Given this list of marker genes COL2A1, AMELX, BGN, CTHRC1, ZP1, FBLN1, PRG2, COL12A1, EMILIN1, HMCN2, COL9A1, AGRN (agrin), ASPN, COLQ, COL6A6, COL25A1, MMRN2, COL1A2, COL5A2, NID2, MUC4, COL7A1, COL5A1, VTN, COL13A1, COL6A5, EMILIN2, ACAN, MUC3A, COL23A1, COL21A1, STATH (NCBI Gene Id 6779), OGN, TNXB, LAMA4, LAMA3, LAMC1, COL1A1, COL19A1, ESM1, THBS2, LAMB3, CHI3L1, ELN, CCN1, LAMA2, COL6A2, COL4A4, PODNL1, COL4A2, CRELD1, COL22A1, DSPP, MUC17, FGL2 (NCBI Gene Id 10875), COL6A1, COL8A2, SRPX2, EFEMP2, LAMA1, COL4A6, LAMA5, VWA1, SPOCK1, COL4A1, MGP, OPTC, ZP2 (NCBI Gene Id 7783), DCN, HSPG2, HAPLN1, AMBN, TUFT1, COL28A1, COMP, MATN3 (NCBI Gene Id 4148), COL4A3, FN1, COL9A2, FBLN5, COL18A1 (collagen type XVIII alpha 1 chain), SPON1 (NCBI Gene Id 84806), MFAP2, COL6A3 (NCBI Gene Id 1293), THBS3, LTBP2, ABI3BP, COL15A1, FBN1, FGB, SPARC, FGA, LAMB1, CHADL, POSTN, PRG4, COL5A3, COL9A3, THBS1, PODN, AEBP1, PRG3, COL4A5, ADIPOQ, MFAP5, HMCN1, TFPI2 (tissue factor pathway inhibitor 2), AMELY, FMOD, TNC (tenascin C), SBSPON, MMRN1, TINAGL1 (tubulointerstitial nephritis antigen like 1), CD4, EFEMP1, LAMC2, CILP, COL11A2, NID1, EMILIN3 (NCBI Gene Id 90187), OTOL1, EDIL3, LTBP4, COL17A1, PXDN, ENAM, IMPG2, ZP4, COL8A1, PRELP, VCAN (NCBI Gene Id 7902), MFGE8 (NCBI Gene Id 54740), NPNT, TECTA, IGFBP7, LAMB2, VWF, THSD4, HAPLN4 (NCBI Gene Id 404037), MEPE, COL14A1, COL16A1, FGG (NCBI Gene Id 2266), TGFBI, LUM, ECM1, FBLN2, MXRA5, LTBP1 (latent transforming growth factor beta binding protein 1), IMPG1, SRPX, PCOLCE, MFAP4, COL24A1 (collagen type XXIV alpha 1 chain), MUC6, DPT, FBN3, COL3A1, COL10A1, TECTB, ZP3, COL27A1, FBN2, MATN2, MATN1, ANOS1, COL11A1, MUC5AC, here is a description of the gene set: species: Homo sapiens The action of a molecule that contributes to the structural integrity of the extracellular matrix. Human Gene Set: GOMF_EXTRACELLULAR_MATRIX_STRUCTURAL_CONSTITUENT